The following is a description of a gene set: studied in species Homo sapiens EPH-ephrin mediated repulsion of cells Human Gene Set: REACTOME_EPH_EPHRIN_MEDIATED_REPULSION_OF_CELLS, and this is the list of marker genes: EPHB1, APH1B, EPHA10, EFNA5, FYN, ACTB, VAV3, ADAM10, MMP9, EFNB3, EPHB3, PSEN1, ACTG1, EFNA2, AP2B1, CLTCL1, AP2M1, EPHA1, AP2S1, VAV2, CLTB, APH1A, TIAM1, AP2A1, EFNA3, PSENEN, EFNA4 (ephrin A4), EPHA8, SRC, EFNB1, EPHA5, AP2A2, EPHA2, PSEN2, EFNA1, EPHB2, EPHB6, EPHB4, RAC1, CLTC, EPHA6, MMP2, EFNB2, LYN, NCSTN, YES1, DNM1, EPHA4, EPHA7, CLTA, EPHA3